Given this list of marker genes RAC1, AP1S3, FYN (FYN proto-oncogene, Src family tyrosine kinase), HCK, CD4, AP2B1, CD28, ELMO1, ARF1, AP1G1, PAK2, LCK, AP1S2, AP2A2, CD247, CD8B, AP1B1, B2M, AP2S1, HLA-A, AP1M1, AP1S1, AP2M1, AP2A1, AP1M2 (NCBI Gene Id 10053), nef, ATP6V1H, DOCK2, PACS1, here is a description of the gene set: part of: Host Interactions of HIV factors Reactome Pathway: The role of Nef in HIV-1 replication and disease pathogenesis studied in species Homo sapiens The HIV-1 Nef protein is a 27-kDa myristoylated protein that is abundantly produced during the early phase of viral replication cycle. It is highly conserved in all primate lentiviruses, suggesting that its function is essential for survival of these pathogens. The protein name "Nef" was derived from early reports of its negative effect on viral replication, thus 'negative factor' or Nef. Subsequently it has been demonstrated that Nef plays an important role in several steps of HIV replication. In addition, it appears to be a critical pathogenic factor, as Nef-deficient SIV and HIV are significantly less pathogenic than the wild-type viruses, whereas Nef-transgenic mice show many features characteristic to HIV disease.<br><br>The role of Nef in HIV-1 replication and disease pathogenesis is determined by at least four independent activities of this protein. Nef affects the cell surface expression of several cellular proteins, interferes with cellular signal transduction pathways, enhances virion infectivity and viral replication, and regulates cholesterol trafficking in HIV-infected cells.